The following is a description of a gene set: Mouse Gene Set: GOBP_REGULATION_OF_PHOSPHATE_TRANSPORT species: Mus musculus Any process that modulates the frequency, rate or extent of phosphate transport. Phosphate transport is the directed movement of phosphate into, out of or within a cell, or between cells, by means of some agent such as a transporter or pore., and this is the list of marker genes: Slc34a1, Cebpb (CCAAT/enhancer binding protein beta), Fgfr4, Ros1, Stc2, Fgfr1, Fgf23, Atf4, Cry2, Sfrp4